The following is a description of a gene set: Pathway Definition from KEGG: KITLG -> KIT -> GRB2 -> SOS -> RAS -> RAF -> MEK -> ERK KITLG-KIT-RAS-ERK signaling pathway. Pathway ID: N00215. Pathway type: Reference. Pathway class: nt06275 Acute myeloid leukemia. Human Gene Set: KEGG_MEDICUS_REFERENCE_KITLG_KIT_RAS_ERK_SIGNALING_PATHWAY studied in species Homo sapiens, and this is the list of marker genes: KIT, MAPK1, NRAS, KITLG, KRAS, BRAF, SOS1, ARAF, MAP2K1, HRAS, MAPK3, RAF1, SOS2, MAP2K2, GRB2